Given this list of marker genes H4c2 (NCBI Gene Id 326620), Ogg1, H2ac10 (NCBI Gene Id 319173), H4c14, H2ac19, H2ac4, Nthl1, H2az2, H2ac20, H4c9, H4c6 (NCBI Gene Id 319157), H4c1, H2bc7, H4c11, Terf1, H2ac13, H2ac7, Tdg, H2ac24, H4c8, H4c4, H4c17 (NCBI Gene Id 100041230), H2bc1, H2ac11, H2ac23, H2ac1, H2ax, Acd, H2bc3, H2bc22, Terf2, H2ac8, H2bc12, Neil1, H2ac22, H4c3, Mpg, Neil2, H2bc8, H4c18, H2ac15, H2bc11, H2ac6, H2bc13, H2ac12, H2bc9, H4c12, H2bc15, Mutyh, Mbd4, H2bc27 (NCBI Gene Id 78303), here is a description of the gene set: electronically inferred by orthology from the curated human pathway This event has been computationally inferred from an event that has been demonstrated in another species.<p>The inference is based on the homology mapping from PANTHER. Briefly, reactions for which all involved PhysicalEntities (in input, output and catalyst) have a mapped orthologue/paralogue (for complexes at least 75% of components must have a mapping) are inferred to the other species. part of: Base Excision Repair Reactome Pathway: Base-Excision Repair, AP Site Formation studied in species Mus musculus